Given this list of marker genes Clec7a (C-type lectin domain family 7, member a), Jak2, Arid5a, Opa1, Mir301, Card9, Brd4, Nlrp10, Ep300, Clec4n, Brd2, Nfkbid, Il23a, Malt1, Nlrp3, Nfkbiz, Tyk2, Mir326, Prkcq, here is a description of the gene set: Any process that activates or increases the frequency, rate or extent of T-helper 17 type immune response. studied in species Mus musculus Mouse Gene Set: GOBP_POSITIVE_REGULATION_OF_T_HELPER_17_TYPE_IMMUNE_RESPONSE